The following is a description of a gene set: Dysarthria studied in species Homo sapiens Dysarthric speech is a general description referring to a neurological speech disorder characterized by poor articulation. Depending on the involved neurological structures, dysarthria may be further classified as spastic, flaccid, ataxic, hyperkinetic and hypokinetic, or mixed. Human Gene Set: HP_DYSARTHRIA, and this is the list of marker genes: NSUN2, MT-ATP6, PDGFRB, FLRT3, SPG21, GSN, NUP54, PIK3CA, HEPACAM, PDGFB, ENTPD1, BBIP1, ACTB, RFC2, PTPN11, FLRT1, KDM6A, VLDLR, CAPRIN1, WDR73, TACO1 (translational activator of cytochrome c oxidase I), PRDM8, CTSF (NCBI Gene Id 8722), GJA1, ZBTB11, ABHD12, SLC13A3, ADGRG1, RNU12, UBA5, PMM2, GDAP2, FBLN1, KMT2D, KCNC3, DUSP6, SOS2, ATG5, VAPB, COX20, TMEM240, PEX12, ATP1A2, IFT74, ATP5MK, ALDH18A1 (NCBI Gene Id 9193), MAPT, EZH2, EXOSC5, AP4M1, THAP1, SPAST, ATL1, CERS1, PLD3, TBCE, ELOVL5, EIF2B2, PON3, MVK, NDUFA6, GAN, RNF220, TBP, BBS10, BAZ1B, HEPHL1, DNAJC6, ELOVL4, BEAN1, ERCC5, STUB1 (STIP1 homology and U-box containing protein 1), GPRC5B, CFAP418, XRCC1, POLE, SPRY4, SLC7A6OS, FOXP2, ATP8A2, GJC2, KMT2B, ATP13A2, MYORG, JPH3, PRRT2, MYOT, DEGS1, PTPN22 (NCBI Gene Id 5779), ATPAF2, NR4A2, OPA3, KCTD7, NDUFS8, ALDH3A2, NDUFS7 (NCBI Gene Id 4727), IRF2BPL, BBS4, GJB1, RFXAP (regulatory factor X associated protein), TRAPPC11, VAMP1 (NCBI Gene Id 6843), NUP62 (nucleoporin 62), RNF170, RNF216, PEX16, GLB1, GFPT1, FAT2, CFAP410, RIT1, ANG, NT5C2, LIMK1, ERCC8, RANBP2, B4GALNT1, REEP1, MTPAP, MPV17, KRAS, VPS13D, CHD3, ATXN8OS, ADD3, JAK2, SATB1, NKX2-1, NCF1, SLC44A1, RRM2B, SCAPER, TTPA, PTRHD1 (peptidyl-tRNA hydrolase domain containing 1), GFAP, MICOS13, RUBCN, RAB39B, PRNP (prion protein (Kanno blood group)), ELN, JAM2, POLR3GL, BUD23, NEFL, REEP2, GCDH, COA8, PUS3, NDNF, DARS2, SEMA3A, DAO, SRCAP, PCNA, TBL2, MRAS (muscle RAS oncogene homolog), ERLIN2, FTH1, MKKS, CLIP2, CLDN11, SLC35A1, CIITA, BBS12, OPTN, ADH1C, POLG2, CHRNE (cholinergic receptor nicotinic epsilon subunit), PEX2, SQSTM1, ZNF592, RFXANK (regulatory factor X associated ankyrin containing protein), EPM2A, GTF2E2, AARS1, ANO10, NDUFAF5, ARSA, FAR1, FARS2, DNAJB6, PRKCG, TMEM163, HACE1 (HECT domain and ankyrin repeat containing E3 ubiquitin protein ligase 1), ELOVL1, MED13L, CEP19, PPARGC1A, VPS41, NARS2, GTF2IRD2, TUBB4A, KCND3, SH3TC2, MTTP, COASY, PDYN, SYNJ1, CHMP2B, NEK1, HTRA1, TACR3, KCNA1, RRAS, PLP1, LMNB1, IFRD1, ERCC2, MSH6, CHEK2, GLE1, ATP2B3 (ATPase plasma membrane Ca2+ transporting 3), ADA2, WFS1, RTTN, DLAT, SNORD118, STAC3, DYNC1I2, FMR1, LZTFL1, CBL, SPR, NONO (NCBI Gene Id 8253), SACS, SIL1, DCC, UBB, ATXN10, IFT27, EIF2B3, HOXB1, FBXL3, TPP1, C19orf12, TTBK2, RFC1, PNPT1, ZC4H2, SCARB2, SAMD9L, AP4B1, FKBP6, CWF19L1 (NCBI Gene Id 55280), NKX6-2, GSS, WDPCP, TWNK, GTF2I, ABCD1, PSEN1, DMXL2, ALS2, OPA1, CCNF, TREX1, CACNA1A, CCDC88C, TAF15, CYP7B1, PPP1R15B, TDP1, TK2, GIPC1, KIF1C, EPCAM, ITPR1, TECPR2, TGFBR2, TANGO2, PIK3R5, PNKD, GBF1, SNCAIP, PCGF2, NOTCH2NLC, MAG, ADAR, AFG3L2, MUTYH (NCBI Gene Id 4595), FUS, SLC20A2, BMPR1A, NDUFAF6, TTC8, SCN1A, SDCCAG8, VPS13A, ATG7, ATXN2, VWA3B, NEFH, WDR11, HLA-B, XRCC4, AUH, ATP5F1D, DNAJC30, WDR62, PPP2R2B, NOP56, DDC, NUBPL, REPS1, NDUFA9, PRPS1, PFN1, PROK2, CP, BBS1, UROC1, VCP, HMGCL, RPIA, METTL27, CBS, DCAF17, PNKP, RRAS2, BRCA2, IFT172, TTR, ATP5F1E, CSTB, BBS7, DAB1, PGM3, UBTF, XPR1, NEB, SCN8A, ATXN3, SLC17A5, ANXA11, LZTR1, TBC1D23, PDE10A, TBK1, TOR1A, PROKR2, ALAD, MAP2K2, SLC18A2, ZFYVE26, CPLX1, EIF4H, ABCB7, KLC2 (kinesin light chain 2), KCNA4, NF2, TSPOAP1, EIF2AK1, DCTN1, SLC25A4, NAXE, TOP3A, CNOT1, HS6ST1, FGF14, AAAS, PSAP, WARS2, ERBB4, SLC30A10, TREM2, GBA2, PRPH, CLN5, HMBS, PON1, COQ4, WDR81, POLG, MECR, AARS2, NUS1, GRHL3, TBC1D24, POLR3A, GFM2, FGFR1, GPT2, AMACR (NCBI Gene Id 23600), NUTM2B-AS1, COQ2, EEF2, SLC19A3, SCO2, PEX6, RAB3GAP2, WIPI2, GALC, SCN5A, SOX10, MATR3, SNCA, SMS, FXN, GRM1, CA8, FTL, CHAMP1, CCDC141, NRAS, NPHP1, SCLT1, TMEM270, CAPN1, AR, ENSG00000288330, RPS20, HESX1 (HESX homeobox 1), CHCHD10, ATP1A3, UBQLN2, HPCA, MLH1, RAF1, HNRNPA1, SPART, COLQ, HLA-DRB1, IL17RD, TTC19, EIF2AK2, POU4F1, ERBB3, FGF8, PANK2 (NCBI Gene Id 80025), TARS1, LYRM7, ATM, SPG11, APOE, PEX10, BBS2, SMARCAL1, ERLIN1, CARS1, RFX5, SLC9A1, CSF1R, MAN2B1, MAP2K1, SPTBN2, PDE8B, TMEM106B, SPRED2, SERPINI1, PRDX3, HYCC1, TMEM63C, ATXN7, MT-TE, GNS, NPC1, TNR, FBXO7, RILPL1, BIN1, ARX, RASA2, UNC13A, RNF113A, UBAP1, SNAP25, CACNA2D2, GPAA1 (glycosylphosphatidylinositol anchor attachment 1), RARS1, CHRNA1, GRIA1, TGM6, AP4E1, GCH1, THG1L, NOTCH3, SOS1, HEXB, RNASEH1, PMPCA, AP4S1, NFASC, ATP5F1A, PPP1R21, PRICKLE1, SLC1A3, THPO, SNAPC4, GCLC, WAC, GTF2IRD1, VPS37D, EIF2B1 (eukaryotic translation initiation factor 2B subunit alpha), LRP12, CTC1 (NCBI Gene Id 80169), SPTAN1, GOSR2, ARL6, PI4KA, ZFHX3, ATP7B, ADCY5, ADPRS, MT-TT, VPS11, BBS9, GLT8D1, SLC25A42, PIEZO2, MT-ATP8, ATCAY (NCBI Gene Id 85300), PLEKHG4, ATXN1 (ataxin 1), C9orf72, MPLKIP, ERCC3, SETX, PABPN1, EPRS1, EBF3, TRIM32, CMPK2, MSH2, PACS1, DARS1 (NCBI Gene Id 1615), GLRX5, ERCC4, SPEG, WASHC5, TIMM8A, BBS5, WWOX, CACNB4, PNPLA6, RAI1, PMS2, TTN, NPPA, SYT14, BRAF, CLN3, PMS1, SLC2A1, CYP27A1, SPG7, CHD7, DRD3, APTX, SOD1, HSD17B10, GBA1, NPC2 (NCBI Gene Id 10577), MARS2, ACBD5, MKS1, PON2, MTRFR, TARDBP, P4HA2, GRIN2A, SYNE1, DCX, CEP290, CLPB (ClpB family mitochondrial disaggregase), POLD1, UCHL1, FIG4, FGF17, HPRT1, SEC31A, MARS1, HSD17B4, POLR3B, FEZF1, PLA2G6, SRPX2 (NCBI Gene Id 27286), EIF2B4, CACNA1G, MRE11, GRID2, STX1A, SELENOI, DDHD2, MMUT, PNPLA8, XK, PRKRA, MPL, SLC16A2, FA2H, ABCA2, SYT2, NHLRC1, RERE, SEMA4A, CISD2, CAMTA1 (calmodulin binding transcription activator 1), GTF2H5, GALT, SUFU, HHAT, TPK1, KCTD17, ANOS1, RYR1, EMC10, ATN1, AQP4, TUBB3, MME, COA7, TRIM37